The following is a description of a gene set: Mouse Gene Set: GOBP_LACTONE_BIOSYNTHETIC_PROCESS The chemical reactions and pathways resulting in the formation of lactone. species: Mus musculus, and this is the list of marker genes: Gulo, Rgn, Ugt1a6a, Akr1b1, Gsto1, Akr1a1